The following is a description of a gene set: Neurologically relevant genes modulated in brain tissue by a trans-regulatory QTL (quantitative trait locus) near D6Mit150 marker. Human Gene Set: CHESLER_BRAIN_D6MIT150_QTL_TRANS studied in species Mus musculus from publication Chesler EJ, Lu L, Shou S, Qu Y, Gu J, Wang J, Hsu HC, Mountz JD, Baldwin NE, Langston MA, Threadgill DW, Manly KF, Williams RW (PMID 15711545) Patterns of gene expression in the central nervous system are highly variable and heritable. This genetic variation among normal individuals leads to considerable structural, functional and behavioral differences. We devised a general approach to dissect genetic networks systematically across biological scale, from base pairs to behavior, using a reference population of recombinant inbred strains. We profiled gene expression using Affymetrix oligonucleotide arrays in the BXD recombinant inbred strains, for which we have extensive SNP and haplotype data. We integrated a complementary database comprising 25 years of legacy phenotypic data on these strains. Covariance among gene expression and pharmacological and behavioral traits is often highly significant, corroborates known functional relations and is often generated by common quantitative trait loci. We found that a small number of major-effect quantitative trait loci jointly modulated large sets of transcripts and classical neural phenotypes in patterns specific to each tissue. We developed new analytic and graph theoretical approaches to study shared genetic modulation of networks of traits using gene sets involved in neural synapse function as an example. We built these tools into an open web resource called WebQTL that can be used to test a broad array of hypotheses., and this is the list of marker genes: HTR4, MAPK1, CALML5, ADRA2B (NCBI Gene Id 151), RELN, MAPK6, GAD1, CHRNG, SLC6A1